Given this list of marker genes FKRP, OS9, GPAA1, FREY1, KDELR1, RER1, ANKRD13C, HSPA5, INSIG2, PDIA2, INSIG1, KDELR2, KDELR3 (NCBI Gene Id 11015), here is a description of the gene set: Any process in which a protein is maintained in the endoplasmic reticulum and prevented from moving elsewhere. These include sequestration within the endoplasmic reticulum, protein stabilization to prevent transport elsewhere and the active retrieval of proteins that escape the endoplasmic reticulum. Human Gene Set: GOBP_MAINTENANCE_OF_PROTEIN_LOCALIZATION_IN_ENDOPLASMIC_RETICULUM species: Homo sapiens